Given this list of marker genes CGA, DIO1, TSHB, DUOX1, DUOX2, TPO, DIO3, IYD, DIO2, SLC5A5, here is a description of the gene set: Human Gene Set: REACTOME_THYROXINE_BIOSYNTHESIS species: Homo sapiens Thyroxine biosynthesis